Given this list of marker genes Shh, Ctnnb1, Ovol2, Sostdc1, Pthlh, Fgfr2, Nog, Wnt2b, Fgf10, Egfr, Luzp1, Trp63, Wnt2, Cfl1, Sulf1, Cecr2, Bmp7, Hhex, Hoxd13, Wnt5a, Gli2, Rdh10, Gdf7, Gatad2a, Bmp4, Nodal, Hif1a, Bmp5, Ar, here is a description of the gene set: studied in species Mus musculus Mouse Gene Set: GOBP_MORPHOGENESIS_OF_AN_EPITHELIAL_FOLD The morphogenetic process in which an epithelial sheet bends along a linear axis.